The following is a description of a gene set: Mouse Gene Set: GOBP_PODOSOME_ASSEMBLY The aggregation, arrangement and bonding together of a set of components to form a podosome, an actin-rich adhesion structure characterized by formation upon cell substrate contact and localization at the substrate-attached part of the cell. species: Mus musculus, and this is the list of marker genes: Mapk8, Dbnl, Tnf (NCBI Gene Id 21926), Rhoa, Arhgef2, Arpc2, Msn, Asb2, Arhgef5, Mapk9, Lcp1, Rho, Bin2, Farp2, Tns3, Diaph3, Il5, Csf2, Gsn, Kif9, Src, Fscn1, Sh3pxd2b, Dock5, Hck